The following is a description of a gene set: Human Gene Set: MIR922 species: Homo sapiens Genes predicted to be targets of miRBase v22 microRNA hsa-miR-922 in miRDB v6.0 with MirTarget v4 prediction scores > 80 (high confidence targets). from publication Chen Y, Wang X (PMID 31504780), and this is the list of marker genes: JOSD2, PCMT1, AP1G1, BNIP3, SOX11, PRKAR2A, STRN3, MLXIP, LYAR, MCTP2, FHL5, UNC13C, AMMECR1L, TICAM2, GPD1, TNPO1, SULF1, ZNF254, PYM1, RBM34, LRP2, SRRM4, PANK2, TTC28, CAMK2D, APH1A, C11orf97, ACSL1, ZNF398, ADSS2, HS3ST2, SLC66A3, NEK7, SEC24C, AGMAT, ZFHX3, CREBZF, STRN, SCP2, USP10, CLIC5, SMPD3, ANKRD28, ATG16L1, BTAF1, IL19, CERT1, PTPN14, DICER1, GOLPH3, SPCS2, ATP2A2, KICS2, LATS2, CAB39L, TFF3, JPH1, CSTF1, REEP1, LATS1, RNF169, LHFPL4, TAOK1, CDK13, NEO1, FBXW7, PLD5, UCHL1, YLPM1, SPRY4, CUL2, ANK3, MICAL2, KCNC2, PCBP1, CCDC88C, SRSF6, DMXL2, GCC2, MTMR4, FRAT2, ATP2B1, SLC8A1 (NCBI Gene Id 6546), SPTY2D1, BAZ2A, ESRRG, CIMAP1A, IHH, SNX12, SLC66A1LP, PPP6C, OSBPL3, ZBTB39, RNF2, GPR85, NAA30, KRTAP24-1, NR4A2, MTF1, CD300LD-AS1, MMS19, ADAMTS19, ARL8A, KDM2A, PRDM6, SLCO6A1, PROX1, ZNF592, NSD1, PI4K2B, FIGN, RC3H1, TAOK3, LGI3, WNT7A, ENTREP1, MBNL1, TMPO, NFYB, SPATS2L, SEC31A, ELOVL4, MSI2, C17orf49, TEX101 (NCBI Gene Id 83639), GPN1, SVEP1, VSTM4, PWWP2A (NCBI Gene Id 114825), PAIP2B, ESR2, GPR156, ARF4, PRR14L, PDLIM5, DLL1, MAP4, PFKFB2, GDNF, ATF1, MIEF2, SFTPB, KRT1, ARID2, MEF2A, ERRFI1, SLC23A2, TBL1XR1, TRIM33, PATL1, SOCS1, GRIA2, MNT, UBR2, ACVR1B, UBE4A, EXOC3L2, ZNF474, USP30, ITGB8, DLK1, TOM1L1, ZNF706, MECOM, TRA2B, RNF213, KBTBD2, TGIF2, HIPK3, THBS2, XPO4, SACS, RIOK2, BMP2, KIF21B, ZNF382, TLK1, FGF14, PHC3, SPRY3, INO80C, STX17, FUNDC1, PTPN23, CLDN18, CDH8, GSK3B (glycogen synthase kinase 3 beta), GPM6B, SPEN, ZNF302, HIF1AN, TTC14, ADGRL2, IRS1